Given this list of marker genes Lyn, Lrp2, Shh, Trf, Gjc2, Nog, here is a description of the gene set: Any process that activates or increases the rate or extent of oligodendrocyte progenitor proliferation. Mouse Gene Set: GOBP_POSITIVE_REGULATION_OF_OLIGODENDROCYTE_PROGENITOR_PROLIFERATION studied in species Mus musculus